Given this list of marker genes SHTN1, TUBB3, UNC5D, DSCAM, UNC5CL, UNC5A, PTK2, UNC5B, UNC5C, here is a description of the gene set: The series of molecular signals initiated by the binding of a netrin protein to its receptor on the surface of the target cell, and ending with the regulation of a downstream cellular process, e.g. transcription. Netrins can act as chemoattractant signals for some cells and chemorepellent signals for others. Netrins also have roles outside of cell and axon guidance. studied in species Homo sapiens Human Gene Set: GOBP_NETRIN_ACTIVATED_SIGNALING_PATHWAY